Given this list of marker genes NELFB, LEO1, SKIC8, POLR2L, GTF2F1, SUPT5H, EAF2, SUPT16H, PAF1, MLLT1, POLR2B, IWS1, ELL, ELOA2, SUPT6H, CDK9, MNAT1, POLR2C, RTF1, GTF2H4, NELFE, POLR2I, CCNT1, SUPT4H1, POLR2E, ELOB, ERCC2 (ERCC excision repair 2, TFIIH core complex helicase subunit), SSRP1, POLR2H, TCEA1, POLR2F, CCNT2, GTF2H2, POLR2G, CDC73, CTDP1, ELOA, MLLT3, POLR2A (NCBI Gene Id 5430), CCNK, NELFA, NCBP1, CCNH, EAF1, ELOC, GTF2H5 (general transcription factor IIH subunit 5), GTF2H1, AFF4, POLR2D, GTF2H3, ERCC3, POLR2J, CDK7, NCBP2, POLR2K, GTF2F2 (general transcription factor IIF subunit 2), NELFCD, CTR9, here is a description of the gene set: studied in species Homo sapiens The mechanisms governing the process of elongation during eukaryotic mRNA synthesis are being unraveled by recent studies. These studies have led to the expected discovery of a diverse collection of transcription factors that directly regulate the activities of RNA Polymerase II and unexpected discovery of roles for many elongation factors in other basic processes like DNA repair, recombination, etc. The transcription machinery and structural features of the major RNA polymerases are conserved across species. The genes active during elongation fall under different classes like, housekeeping, cell-cycle regulated, development and differentiation specific genes etc. The list of genes involved in elongation has been growing in recent times, and include: -TFIIS,DSIF, NELF, P-Tefb etc. that are involved in drug induced or sequence-dependent arrest - TFIIF, ELL, elongin, elongator etc. that are involved in increasing the catalytic rate of elongation by altering the Km and/or the Vmax of Pol II -FACT, Paf1 and other factors that are involved chromatin modification - DNA repair proteins, RNA processing and export factors, the 19S proteasome and a host of other factors like Spt5-Spt5, Paf1, and NELF complexes, FCP1P etc.. Elongation also represents processive phase of transcription in which the activities of several mRNA processing factors are coupled to transcription through their binding to RNA polymerase (Pol II). One of the key events that enables this interaction is the differential phosphorylation of Pol II CTD. Phosphorylation pattern of CTD changes during transcription, most significantly at the beginning and during elongation process. TFIIH-dependent Ser5 phosphorylation is observed primarily at promoter regions while P-Tefb mediated Ser2 phosphorylation is seen mainly in the coding regions, during elongation. Experimental evidence suggests a dynamic association of RNA processing factors with differently modified forms of the polymerase during the transcription cycle.. part of: RNA Polymerase II Transcription Reactome Pathway: RNA Polymerase II Transcription Elongation